The following is a description of a gene set: Human Gene Set: GOMF_N_ACETYLLACTOSAMINE_SYNTHASE_ACTIVITY studied in species Homo sapiens Catalysis of the reaction: UDP-galactose + N-acetyl-D-glucosamine = UDP + N-acetyllactosamine., and this is the list of marker genes: B4GALT1, B4GALT4, B4GALT5, B4GALT3, B4GALT2